Given this list of marker genes ADA, here is a description of the gene set: studied in species Homo sapiens Normally in humans, adenosine and deoxyadenosine can be deaminated to inosine and deoxyinosine, catalyzed by ADA (adenosine deaminase). In the absence of ADA activity, however, accumulated nucleosides disrupt lymphoid cell function, leading to severe combined immunodeficiency. part of: Nucleotide salvage defects Reactome Pathway: Defective ADA disrupts (deoxy)adenosine deamination